The following is a description of a gene set: studied in species Homo sapiens Reactome Pathway: Apoptotic cleavage of cellular proteins part of: Apoptotic execution phase Apoptotic cell death is achieved by the caspase-mediated cleavage of various vital proteins. Among caspase targets are proteins such as E-cadherin, Beta-catenin, alpha fodrin, GAS2, FADK, alpha adducin, HIP-55, and desmoglein involved in cell adhesion and maintenance of the cytoskeletal architecture. Cleavage of proteins such as APC and CIAP1 can further stimulate apoptosis by produce proapoptotic proteins., and this is the list of marker genes: TJP2, GAS2, VIM, PKP1, CASP3, STK26, TJP1, PRKCQ, BMX (NCBI Gene Id 660), DBNL, PLEC, ROCK1, SPTAN1, DSG1, FNTA, CDH1, DSP, CTNNB1, DSG2, CASP6, GSN, OCLN, CASP7, ACIN1, STK24, BIRC2, APC, ADD1, LMNB1, PRKCD, BCAP31 (NCBI Gene Id 10134), MAPT (microtubule associated protein tau), LMNA, DSG3 (NCBI Gene Id 1830), PTK2, CLSPN, SATB1, CASP8